The following is a description of a gene set: species: Homo sapiens Human Gene Set: GOBP_ARTERY_SMOOTH_MUSCLE_CONTRACTION A process in which force is generated within smooth muscle tissue, resulting in a change in muscle geometry. This process occurs in the artery. Force generation involves a chemo-mechanical energy conversion step that is carried out by the actin/myosin complex activity, which generates force through ATP hydrolysis. The artery is a vessel carrying blood away from the heart., and this is the list of marker genes: EDNRA, BBS2, SCNN1B, EDN3 (NCBI Gene Id 1908), GRIP2, EDN2, MKKS, EDN1, CD38, HTR2A